Given this list of marker genes PLCB2, PLCB3, GNA11, GNA14, GNA15, GNAQ, FFAR1, PLCB1, here is a description of the gene set: Fatty acids augment the glucose triggered secretion of insulin through two mechanisms: intracellular metabolism and activation of FFAR1 (GPR40), a G-protein coupled receptor. Based on studies with inhibitors of G proteins such as pertussis toxin FFAR1 is believed to signal through Gq/11. Binding of free fatty acids by FFAR1 activates the heterotrimeric Gq complex which then activates Phospholipase C, producing inositol 1,4,5-trisphosphate and eventually causing the release of intracellular calcium into the cytosol. From experiments in knockout mice it is estimated that signaling through FFAR1 is responsible for about 50% of the augmentation of insulin secretion produced by free fatty acids. species: Homo sapiens part of: Free fatty acids regulate insulin secretion Reactome Pathway: Fatty Acids bound to GPR40 (FFAR1) regulate insulin secretion